Given this list of marker genes TAS2R8, TAS2R50, TAS2R39, TAS2R14, TAS2R45, TAS2R42, TAS2R19, TAS2R16, TAS2R7, TAS2R4, TAS2R9, TAS2R41, TAS2R43, TAS2R1, TAS2R20, TAS2R3, TAS2R10, TAS2R46, TAS2R13, TAS2R30, TAS2R60, TAS2R38, TAS2R31, TAS2R40, TAS2R5, here is a description of the gene set: species: Homo sapiens Human Gene Set: GOMF_BITTER_TASTE_RECEPTOR_ACTIVITY Combining with soluble bitter compounds to initiate a change in cell activity. These receptors are responsible for the sense of bitter taste.